Given this list of marker genes C22orf39, DGCR6, SLC25A1, MRPL40, RANBP1, CLDN5, PRODH, ZDHHC8 (zinc finger DHHC-type palmitoyltransferase 8), ARVCF, GP1BB, TXNRD2, TANGO2, ENHO, HIRA, RTN4R, UFD1, TRMT2A (NCBI Gene Id 27037), ESS2, COMT, FOXN3, SNORA74A, DGCR2, DGCR8 (NCBI Gene Id 66034), here is a description of the gene set: Human Gene Set: STARK_HYPPOCAMPUS_22Q11_DELETION_DN studied in species Mus musculus Genes down-regulated in hyppocampus of mice carrying a hemizygotic microdeletion in the 22q11.2 region. Individuals with 22q11.2 microdeletions show behavioral and cognitive deficits and are at high risk of developing schizophrenia. We analyzed an engineered mouse strain carrying a chromosomal deficiency spanning a segment syntenic to the human 22q11.2 locus. We uncovered a previously unknown alteration in the biogenesis of microRNAs (miRNAs) and identified a subset of brain miRNAs affected by the microdeletion. We provide evidence that the abnormal miRNA biogenesis emerges because of haploinsufficiency of the Dgcr8 gene, which encodes an RNA-binding moiety of the 'microprocessor' complex and contributes to the behavioral and neuronal deficits associated with the 22q11.2 microdeletion. from publication Stark KL, Xu B, Bagchi A, Lai WS, Liu H, Hsu R, Wan X, Pavlidis P, Mills AA, Karayiorgou M, Gogos JA (PMID 18469815)